Given this list of marker genes RN7SKP30 (NCBI Gene Id 106479108), LINC02928, ARL9, RNU6-998P, REST, GLDCP1, CHAER1, RNU6-197P, RASL11B, FCF1P8, SPMAP2L, CRACD, IGFBP7-AS1, EXOC1L, PDGFRA, SCFD2, SRD5A3-AS1, RN7SL357P, HOPX, RN7SL424P, RPL21P44, KIT, RPL7AP31, IGFBP7, RPL17P20, SRIP1, MORF4L2P1, LNX1-AS2, NOA1, KDR, RPL22P13 (NCBI Gene Id 442108), LINC01618, UBE2CP3, AASDH, DUTP7, RPS26P24, USP46-DT, LRRC34P2, SPINK2, SGCB, CEP135, MIR4449 (NCBI Gene Id 100616436), SPATA18, RNU6-410P, RNU6-276P, RNU6-310P, PDCL2 (phosducin like 2), PPAT, CHIC2, RNU6-746P, LNX1-AS1, DCUN1D4, RN7SL492P, PAICS, RNA5SP161 (RNA, 5S ribosomal pseudogene 161), LINC02283, LNX1, USP46, GSX2, ENSG00000287382, ENSG00000212490, POLR2B, ENSG00000249341, SRP72, MRPL22P1, SRD5A3, LINC02380, METTL5P3, LINC02260, TMEM165, CLOCK, LINC02480, ENSG00000299934, COMMD5P1, DANCR, RNU6-1252P, LRRC66, SNORA26, EXOC1, ERVMER34-1, RPL38P3, LINC02358, NMU, RN7SL822P, FIP1L1, RNU6-652P, here is a description of the gene set: studied in species Homo sapiens Human Gene Set: chr4q12